The following is a description of a gene set: Any process that results in a change in state or activity of a cell or an organism (in terms of movement, secretion, enzyme production, gene expression, etc.) as a result of a nutrient stimulus. studied in species Homo sapiens Human Gene Set: GOBP_RESPONSE_TO_NUTRIENT, and this is the list of marker genes: ASS1 (argininosuccinate synthase 1), PLD1, GNAI2, BMP7, CDKN2B, HMGCS2, BECN1, CYP26B1, KYNU, XBP1, CXCL10, SRF, NFE2L2, GIPR, TSPO, TFRC, TBXA2R, ALAD, AGL, PTH, FOLR2 (NCBI Gene Id 2350), ASCL1, VDR, SREBF1, MAF, TFAM, ARSB, GATA4, C2, PPARA, EPO, GCGR, DNMT3A, SLC34A1, CD40, BGLAP, RPS6KB1, FGF23, SLC27A4 (NCBI Gene Id 9176), GCLC, KAT2B, LIPG, CASR, BCKDHB, PENK, CYP24A1, PDK2, GPRIN3, ADIPOQ, ENSA, NOD2, MAT2A, SPP1, SNAI2, PKLR, MT-CYB, UCP3, SLC6A4, MLXIPL, ABCG5, CSNK1A1, POR, SFRP2, CYP26A1, USF1, CCL28, TRIM24, ADSL, ACSL1 (NCBI Gene Id 91249), LRAT, GDAP1, PDX1, CBS, TMIGD1, USF2, MAP1B, LPL, AMELX, CAT, EEF2, MDM2, TGFB1, FOLR1, OXCT1, MED1, SFRP1, GAS6, HLCS, AKR1C3, VCAM1, GPX1, COL1A1, SAMTOR, MLYCD, SST, NNT, TPCN2, MAFB, SOD2, STC2, POSTN, TRIM25, FES, RXRA, LTA, KL, MTOR, RXRB, CPT1A, SLC16A1, CYP1A1 (NCBI Gene Id 1543), STC1, RARA, OGT, NCOA1, SNW1 (NCBI Gene Id 22938), AQP3, SCAP, IGFBP2 (insulin like growth factor binding protein 2), PPARD, ABCB1, TYR, HSF1, ABCA1, NCOA3, OTC, ITGA2, ACACB, ALDH1A2, PRMT1, RELA, BCHE, KANK2, TNC, COX4I1, PIM1, MIR125B1, MN1, SLC6A19, CDKN2D, GSTP1, CD4, LIPA, GCLM, FASN, PHEX, LEP, APAF1, F7, ALPL, PPARG, STAT1, CYP27B1, CCND1, DGAT2, ABCG8, CYBB, ENSG00000274276, MTHFR, NFKBIZ, F5, CEBPA (CCAAT enhancer binding protein alpha)